The following is a description of a gene set: species: Mus musculus Mouse Gene Set: MIR_7042_3P Genes predicted to be targets of miRBase v22 microRNA mmu_miR_7042_3p in miRDB v6.0 with MirTarget v4 prediction scores > 80 (high confidence targets). from publication Chen Y, Wang X (PMID 31504780), and this is the list of marker genes: Arl8b, Shoc2, Pip4k2b (NCBI Gene Id 84507), Msh4, Fnta, Gnpat, Ugcg, Cpn2, Foxf1, Hip1, Gpr17, Gp1bb, Ccnd2, Pabir2, Dyrk1a, Gpm6a, Brk1, Socs7, Il5, Pigc, Khdrbs1, Vipr1, Cpd, Prpf38b, Phf13, Fam174c, Adad2, Spn, Nlgn1 (NCBI Gene Id 99949), Gabrb3 (GABRB3, gamma-aminobutyric acid type A receptor subunit beta 3), Kctd1, Igsf5, Coro1b, Gadd45a, Sh2b3, Dpp4, Trpc4, Klhl25, Nanos1, Adam28, Sp6, Mospd2, Paqr4, Zpld1, Egflam, Ifi211, Trp53inp1, Iqsec1, Zfp367, Pfn2, Gspt1, Plxna1, Btc, Tmod3, Efna5, Ssbp3, Zcchc24, Nr4a2, Pex5l, Psapl1 (prosaposin-like 1), Mall, Ilrun, Ap1s3, Hbs1l, Coro1c, Mag, Dnajc11, Fam114a1 (family with sequence similarity 114, member A1), Yy1, Arhgap11a, Lrrc20, Alad (aminolevulinate, delta-, dehydratase), Znrf2, Dgkz, Sox6, Pspc1, Fam20a, Hhat, Gapvd1, Zc4h2, Sox11, Bnip2, Fbxo11, Hipk1, Vcf1, Hes2, Wsb1, Cd164l2, Asah1, Chrna10, Tbc1d4